Given this list of marker genes Emp1, Nid1, Lamb1, Hspg2, Cldn5, Vtn, Col4a2, Itga4, Col3a1, Cdh5, Mylip, Col4a1, Ramp2, Nid2, Tgfb1i1, here is a description of the gene set: Mouse Gene Set: HEVNER_TELENCEPHALON_VASCULAR_ENDOTHELIUM_AND_MENINGEAL_CELLS Genes selectively expressed by meningeal cells and vascular endothelium in embryonic day 14.5 mouse telencephalon. from publication Bedogni F, Hevner RF (PMID 34321999) species: Mus musculus